The following is a description of a gene set: Any process that stops, prevents or reduces the frequency, rate or extent of an oxidative stress-induced intrinsic apoptotic signaling pathway. species: Homo sapiens Human Gene Set: GOBP_NEGATIVE_REGULATION_OF_OXIDATIVE_STRESS_INDUCED_INTRINSIC_APOPTOTIC_SIGNALING_PATHWAY, and this is the list of marker genes: FYN, INS, HSPB1, PPIA, PRKN, NME5, PARK7, NONO, MIR195 (NCBI Gene Id 406971), FGF2, SOD2, SIRT1, RACK1, HIF1A, MIR92A1, MAPK7, GPX1, WNT1, IL10, ATF4, TRAP1, FZD1, NFE2L2, BAG5, MIR133A1 (NCBI Gene Id 406922), MIR19A, GATA4, PYCR1, CTNNB1, FBXO7 (NCBI Gene Id 25793), MIR29B1, PINK1, AKT1, NOL3, HTRA2